The following is a description of a gene set: A state of excessive motor activity that is associated with mental distress or a feeling of substantial unease or inner tension. Distinguished from restlessness by the increased level of emotional distress and negative intensity of the experience. Agitation has a significant level of physical activity that is typically threatening to the self or others. Human Gene Set: HP_AGITATION Agitation studied in species Homo sapiens, and this is the list of marker genes: ADA2, PSEN2, GABBR2, TREM2, EIF4G1, TSHR, TMEM67, MECP2, FGF12, SUOX, HTRA2, DCDC2, BRAT1, UCP2, PAK3 (p21 (RAC1) activated kinase 3), LSS, PARK7, PRKN, GNS, NTNG1, HSD17B10, CDKL5, PSEN1, SATB1 (SATB homeobox 1), ACAT1 (acetyl-CoA acetyltransferase 1), ABCC8, VPS13C, PTS, UCHL1 (NCBI Gene Id 7345), KIF11, PDE11A, PODXL, ATP6V0A1, GLS, ALAD, LRRK2, NAGS, GRN, DEAF1, ECE1, HTT, PINK1, ABCA7, DNAJC6, HNF4A, DCX, DNAJC13, SLC2A3, ADCY5, APP, KCNJ11, NDST1, GNAS, GBA1, SPAST, TOMM40, FMR1, SYNJ1, CACNA1A, COX10, GIGYF2, IGF1R, HNF1A, VPS35, SPTBN1 (NCBI Gene Id 91654), H4C5, WAC, SMC1A, MED13L, GCSH, SNCA, SYT1, TRANK1, PRKAR1A (NCBI Gene Id 5573), SORL1, ZFX, AFF2, EIF2S3, CYP27A1